The following is a description of a gene set: Any of a group of soluble proteins functioning in the activation of ribosome-mediated translation of mRNA into a polypeptide. Mouse Gene Set: GOMF_TRANSLATION_ACTIVATOR_ACTIVITY species: Mus musculus, and this is the list of marker genes: Rps27l, Paip1, Mif4gd, Ctif, Larp1, Pcbp1 (NCBI Gene Id 23983), Dhx29, Boll, Dazl, Abcf1